Given this list of marker genes Zscan20, Zfp947, Ikzf1, Mettl3, Adgrl4, Tll1 (NCBI Gene Id 21892), Plppr5, Sowahc, Ubr3, Camkk1, Bclaf1, Atp9b, Rpp14, Anp32a, Aco1, Ube2d3, Pak3, Marcks, Sall4, Hipk3, Tsc22d2, Tchh, Lipo1, Zfp758, Zfp268, Mynn, Slc16a7, Rlim, Kcnc2, Stoml2, Fbxo45, Zfp987, Tead1, Dtna, Hdac9, Pon2, Rybp, Agpat1, Pcdh11x, Rgs8, Nppb, Krt81, Purb, Sytl4, Tgfbr1, Hhip, Sumf2, Zfp113, Npy2r, Ube2w, Kdm7a, Rab11fip2, Slc6a3, Lif, Ncam2, Zfp994, Zbtb11, Xlr5b, Zfp985, Rnf34, Luc7l3, Miga1, Kcnd2, Prr16, Ptprb, Bend6, E2f5, Dcaf11, Ror1, Igsf9b, Mtf1, Rasgrp1, Kctd12b, Ttc32, Nova1, Cers2, Serpina3i, Aurkc, Magi1 (NCBI Gene Id 78178), Dlat, Lrch2, Rc3h2, Usp15, Phldb2, Ift81, Snx10, Acvrl1, Ino80d, Cldn23, Nr2f1, Zfp984, Pate5, Nol10, Cd300e, Proser1, Matr3, Bet1, Rnf150 (NCBI Gene Id 77483), Gm8978, Tmem128, Dppa5a, Zfp992, Irak2, Ppp4r2, Slc35f5, Il33, Dab1, Esrp1, Itga6, Smg1, Zfp991 (zinc finger protein 991), Ppp4r3b, Ccdc59, Tram1, Dnaja1, Zfp74, here is a description of the gene set: Genes predicted to be targets of miRBase v22 microRNA mmu_miR_6917_3p in miRDB v6.0 with MirTarget v4 prediction scores > 80 (high confidence targets). studied in species Mus musculus Mouse Gene Set: MIR_6917_3P from publication Chen Y, Wang X (PMID 31504780)